Given this list of marker genes Lhx6, Gm9967, Fam222a, Gm11346, Gm12068 (predicted gene 12068), Nol4, Dclk2, Tpgs2, Nr2c2ap, Sox2ot, Slc18a2, B020031H02Rik, Dlx6os2, Gm57504, Gm19335, Trpc4, Dlx5, Lhx8, Gm20515, Nxph2, Slc4a11, Slc6a1, Dlx1, Smim45, Cntnap3, 4930558K02Rik, Dlx2, Grik3, Dlx1as, Sp9, Gm10248, Nkx2-1, Vmn2r1, Dlx6, Hepacam2, Arx, 4933430M04Rik, Kctd21 (NCBI Gene Id 630769), Dlx6os1, Myo3a, Calb1, Gm38505, here is a description of the gene set: studied in species Mus musculus from publication Cao J, Spielmann M, Qiu X, Huang X, Ibrahim DM, Hill AJ, Zhang F, Mundlos S, Christiansen L, Steemers FJ, Trapnell C, Shendure J (PMID 30787437) Mouse Organogenesis Cell Atlas (MOCA) DE_gene_main_cluster.csv, fold.change>=1.5, qval<0.05, pval<0.05 Mouse Gene Set: DESCARTES_ORGANOGENESIS_INHIBITORY_INTERNEURONS